The following is a description of a gene set: from publication Chen Y, Wang X (PMID 31504780) Genes predicted to be targets of miRBase v22 microRNA hsa-miR-3975 in miRDB v6.0 with MirTarget v4 prediction scores > 80 (high confidence targets). studied in species Homo sapiens Human Gene Set: MIR3975, and this is the list of marker genes: PLXNA4, TPD52L2, MYO1H, GABPB2, RNF24, KICS2, MIER3, DPYSL3, NRG3, PHTF2, PTGR3, UBE2I, ERAP2, ZNF770, CCN2, ETNK1, STAU2, BCAP29, MBD6, NABP1, USP7, SNX3, APLP2 (amyloid beta precursor like protein 2), SLC26A6, EOGT, ERG28, GSR, TDRP, OGT, EPHA4, TMEM86A, NAV3, CLDN12, SEC24C, ZNF541, TEAD1, ENDOV, ZXDB (NCBI Gene Id 7790), SLC15A2, HOXB13, GLYAT, PRUNE2, ZBTB18, NPAS3, DRP2, SUOX, ANKUB1, GPHN, ZBTB41, INSR, ANKRD6 (ankyrin repeat domain 6), USP47, MITF